The following is a description of a gene set: Catalysis of an oxidation-reduction (redox) reaction in which an aldehyde or ketone (oxo) group acts as a hydrogen or electron donor and reduces a disulfide. Mouse Gene Set: GOMF_OXIDOREDUCTASE_ACTIVITY_ACTING_ON_THE_ALDEHYDE_OR_OXO_GROUP_OF_DONORS_DISULFIDE_AS_ACCEPTOR species: Mus musculus, and this is the list of marker genes: Ogdh, Bckdha, Pdha1, Pdhb, Bckdhb, Ogdhl, Pdha2, Dhtkd1